Given this list of marker genes ATP1A2, CACNA1A, PRRT2 (proline rich transmembrane protein 2), PMP22, SCN1A, here is a description of the gene set: Human Gene Set: HP_SPONTANEOUS_PAIN_SENSATION studied in species Homo sapiens Spontaneous pain is a kind of neuropathic pain which occurs without an identifiable trigger. Spontaneous pain sensation